Given this list of marker genes Mbtps1, Creb3, Creb3l3, Mbtps2, Crebrf, here is a description of the gene set: Mouse Gene Set: REACTOME_CREB3_FACTORS_ACTIVATE_GENES CREB3 factors activate genes studied in species Mus musculus